Given this list of marker genes SPCS1, GNAT3, FFAR1, GNG13, SPCS3, SEC11C, CTNNB1, GATA4, LEP, GNB1, GRP, PCSK1, PAX6, GCG, GPR119, FFAR4, CDX2, DPP4, ISL1, GIP, TCF7L2, SEC11A, SPCS2, GNB3, here is a description of the gene set: studied in species Homo sapiens part of: Peptide hormone metabolism Incretins are peptide hormones produced by the gut that enhance the ability of glucose to stimulate insulin secretion from beta cells in the pancreas. Two incretins have been identified: Glucagon-like Peptide-1 (GLP-1) and Glucose-dependent Insulinotropic Polypeptide (GIP, initially named Gastric Inhibitory Peptide). Both are released by cells of the small intestine, GLP-1 from L cells and GIP from K cells.<br>The control of incretin secretion is complex. Fatty acids, phospholipids, glucose, acetylcholine, leptin, and Gastrin-releasing Peptide all stimulate secretion of GLP-1. Fatty acids and phospholipids are the primary stimulants of secretion of GIP in humans (carbohydrates have more effect in rodents).<br>Incretins secreted into the bloodstream are subject to rapid inactivation by Dipeptidyl Peptidase IV (DPP IV), which confers half-lives of only a few minutes onto GLP-1 and GIP. Inhibitors of DPP IV, for example sitagliptin, are now being used in the treatment of Type 2 diabetes. Reactome Pathway: Incretin synthesis, secretion, and inactivation